The following is a description of a gene set: Signaling pathways invoke interplays between forward signaling and feedback to drive robust cellular response. In this study, we address the dynamics of growth factor signaling through profiling of protein phosphorylation and gene expression, demonstrating the presence of a kinetically defined cluster of delayed early genes that function to attenuate the early events of growth factor signaling. Using epidermal growth factor receptor signaling as the major model system and concentrating on regulation of transcription and mRNA stability, we demonstrate that a number of genes within the delayed early gene cluster function as feedback regulators of immediate early genes. Consistent with their role in negative regulation of cell signaling, genes within this cluster are downregulated in diverse tumor types, in correlation with clinical outcome. More generally, our study proposes a mechanistic description of the cellular response to growth factors by defining architectural motifs that underlie the function of signaling networks. from publication Amit I, Citri A, Shay T, Lu Y, Katz M, Zhang F, Tarcic G, Siwak D, Lahad J, Jacob-Hirsch J, Amariglio N, Vaisman N, Segal E, Rechavi G, Alon U, Mills GB, Domany E, Yarden Y (PMID 17322878) Human Gene Set: AMIT_EGF_RESPONSE_20_HELA studied in species Homo sapiens Genes whose expression peaked at 20 min after stimulation of HeLa cells with EGF., and this is the list of marker genes: PRKAR1B, FOS, BTG2, PPP1R15A, SNAP25, TXNIP, GADD45B, ROCK2, NPIPA1, ZC3H12A, PILRB, JUN